Given this list of marker genes FAM120A, UBE2E1, UBAP2L, LYPLA1, PPP1R7, PSMB2, UBA2, SUMO3, MYL11, HNRNPC, RAB1A, IST1, NACA (nascent polypeptide associated complex subunit alpha), DCTN2, RAD21, HTATSF1, SLC25A3, ARCN1, TIAL1, MAML1, G3BP1, SRP19, MDH1, PCNA, DLD, IFT25, ATP5F1C, RPL36AL, CCT2, SOD1, CUL1, HSP90AA1, ATP5MF, POLR2I, UTP18, GDI2, TPGS2, MBD4, CYC1, STARD7, SNRPE, RPA1, COX6C, MTDH, COPB1, IK, PDCD6, RBL2, SEC13, WIPI2, YWHAQ, PSMC1, NONO, KPNA2, MSH2, SHMT1, FBXW11, DEK, ETFA, COIL, ATP5PF, SRSF9 (serine and arginine rich splicing factor 9), MTA1, SMG7, KBTBD2, RAC1, COPS5, EEF1D, ZZZ3, TMED2, MORF4L2, CNIH1, PSMD8 (proteasome 26S subunit, non-ATPase 8), TMBIM6, PPP1CA, COX7B, H2AZ1, SMARCD2, EIF3C, PSMA4, TBCA, RBMX, POLE3, HAT1, CUX1 (NCBI Gene Id 1523), SSBP1, HDAC2, PSMB7, BUD31, ILF2, RAN (RAN, member RAS oncogene family), BZW1, ILF3, PRMT1, ENSA (NCBI Gene Id 51620), NDUFS1, CSNK2B, COX7A2L, SKP1, UBR5, SUMO1, KARS1, SYPL1, SPCS2, HPRT1, BCAP31, DARS1, SEM1, SRP9, UQCRC2, SDHA, UBE2L3, DRG1, CBX3, C6orf62, CNBP, HSPA9, EBAG9, ELOC, BANF1, RHEB, SNRNP200, YWHAB, HNRNPAB, PSMA2, LSM3 (NCBI Gene Id 27258), IFRD1, ANP32B, NDUFS3, PCLAF, UQCRB, HNRNPU, PSMC6, C1QBP, PRKAR1A, COX5A, DPM1, KIF2A, HNRNPA3P1, GATD3, POLR2G, HSPA8, FAM20B, STOML2, PRPSAP1, GMFB, SF3B2, PPP2CA, DNPEP, HMGN1, U2AF1, RAD23B, SET, PSMB4 (proteasome 20S subunit beta 4), HNRNPM, SNRPG, MRPL9, SMNDC1, PARK7, KHDRBS1, EIF4H, TAF11, COX4I1, CANX, PUF60, USP1 (ubiquitin specific peptidase 1), SYNCRIP, COA1, METAP1 (methionyl aminopeptidase 1), COX6A1, AP3S1, SP3, CFDP1 (NCBI Gene Id 10428), PSMD7, PSMC2, SUMO2, NDUFA5, HNRNPA2B1, CTCF, SEC61G, here is a description of the gene set: species: Homo sapiens Human Gene Set: MORF_RAD21 Neighborhood of RAD21 Neighborhood of RAD21 RAD21 homolog (S. pombe) in the MORF expression compendium